Given this list of marker genes Serpinb6b, Casp1, Serpine1, Serpinb6e, Serpinb6a, Cstdc3, Cstdc5, Stfa2l1, Serpina5, Ctsb, Klk8, Cstdc6, Serpinb6c, Serpinb6d, Plau, Csta3, Plat, Csta2, Stfa1, Vtn, Stfa2, Csta1, Stfa3, Cstdc4, here is a description of the gene set: studied in species Mus musculus A protein complex which is capable of peptidase inhibitor activity. Mouse Gene Set: GOCC_PEPTIDASE_INHIBITOR_COMPLEX